The following is a description of a gene set: Catalysis of the movement of phospholipids from one membrane bilayer leaflet to the other, by an ATP-independent mechanism. Mouse Gene Set: GOMF_PHOSPHOLIPID_SCRAMBLASE_ACTIVITY studied in species Mus musculus, and this is the list of marker genes: Xkr8, Xkr9, Ano9, Ano1, Ano7 (anoctamin 7), Ano4, Ano2, Atg9b, Clptm1l, Ano8, Plscr3, Tmem41b (transmembrane protein 41B), Plscr1l1, Serinc3, Ano5, Serinc5, Serinc2, Plscr1, Ano6, Ano10, Vmp1, Xkr4, Vdac2, Plscr4, Ano3, Atg9a, Plscr2, Plscr5